Given this list of marker genes OSBPL5, RANBP9, ZNF597, RSPRY1, EEF1AKMT4-ECE2, BBOF1 (NCBI Gene Id 80127), AIDA, TRIM37, PDCD2, ECE2, ATP2A1, CCT2, MAGI1, DLG5, DTX1, here is a description of the gene set: from publication Chen Y, Wang X (PMID 31504780) studied in species Homo sapiens Genes predicted to be targets of miRBase v22 microRNA hsa-miR-4462 in miRDB v6.0 with MirTarget v4 prediction scores > 80 (high confidence targets). Human Gene Set: MIR4462